Given this list of marker genes ZNF626, PPP2R1B, IL1RAPL2, AFF4, SCG2, FAM133A, TTLL7, CD93, DGKE, TAFA1, M6PR, NFIX, CAMK1D, ELOVL2, TRAM2, ARK2C, CTBP2, SAMD5, ABL1, CD80, KIF5B, TYMSOS, SLC13A3, IL10, ATP1B2, ZNHIT3, ERGIC1, LRR1, VGLL4, HGSNAT, MAP3K9, IGFBP5, TTC33, DPPA4, EBF4, POFUT1, CYRIB, RNMT, TRIM22, SFTPA1, YTHDF1, SKAP2, ZNF516, ARMH3, SUFU, ACTC1, ZMAT3, CHIC1, MAPK1, ARHGAP24, RUBCN, ZDHHC2, NHSL3, MMP14, HMGA1, MYO1D, ATP6V0B, ZNF609, PIGG, ASF1A, UBE4B, ARL8B, KLHL20, OCIAD2, CDK2, LRP11, HIF3A, ZNF585A, SGPL1, RBBP7, TRPM1, ARL3, EEIG1, VOPP1, SAMD12, FMR1, OPCML, CARTPT, TWIST1, PTGFRN, RBPMS, PSORS1C2, S1PR3, RFX3, RNF212, DTNA, EFNA5, RMND5A, NRG3, OSBPL9, CA12, CSMD1, ACYP2, MTMR10, USP37 (ubiquitin specific peptidase 37), HPSE2, CBLN1, SEC22C, ONECUT2, POC1B-GALNT4, RAB5B (NCBI Gene Id 5869), EYA3, GUCY1A2, RNF185 (ring finger protein 185), TXNIP, TOR2A, HSP90AA1, PARG, TMEM161B, LRTOMT, EXOC2 (NCBI Gene Id 55770), HDX, VANGL2, HAO2 (hydroxyacid oxidase 2), HNRNPK, HPGD, AFAP1L2, RAD54B, PSME3, EHHADH, PDE6A, TTC1, KCNJ13, SZT2, TNS4, RPS6KC1, GALNT4, KCND1, CASR, LEMD2, ADAM19, RAB3C, TFRC, GNG12, COX6B1 (NCBI Gene Id 1340), ASTN1, TUSC3, MAN1C1, CD34 (NCBI Gene Id 947), IFFO2, TMPPE, TRIM35, FRS3, TAFA5, ZFHX4, ZNF550, PIGR, DOCK5, EXPH5, VAX1, RALGAPB, DMWD, SH3TC2, here is a description of the gene set: Genes predicted to be targets of miRBase v22 microRNA hsa-miR-6847-5p in miRDB v6.0 with MirTarget v4 prediction scores > 80 (high confidence targets). from publication Chen Y, Wang X (PMID 31504780) Human Gene Set: MIR6847_5P species: Homo sapiens